The following is a description of a gene set: Hepatocellular carcinoma (HCC) is a highly heterogeneous disease, and prior attempts to develop genomic-based classification for HCC have yielded highly divergent results, indicating difficulty in identifying unified molecular anatomy. We performed a meta-analysis of gene expression profiles in data sets from eight independent patient cohorts across the world. In addition, aiming to establish the real world applicability of a classification system, we profiled 118 formalin-fixed, paraffin-embedded tissues from an additional patient cohort. A total of 603 patients were analyzed, representing the major etiologies of HCC (hepatitis B and C) collected from Western and Eastern countries. We observed three robust HCC subclasses (termed S1, S2, and S3), each correlated with clinical parameters such as tumor size, extent of cellular differentiation, and serum alpha-fetoprotein levels. An analysis of the components of the signatures indicated that S1 reflected aberrant activation of the WNT signaling pathway, S2 was characterized by proliferation as well as MYC and AKT activation, and S3 was associated with hepatocyte differentiation. Functional studies indicated that the WNT pathway activation signature characteristic of S1 tumors was not simply the result of beta-catenin mutation but rather was the result of transforming growth factor-beta activation, thus representing a new mechanism of WNT pathway activation in HCC. These experiments establish the first consensus classification framework for HCC based on gene expression profiles and highlight the power of integrating multiple data sets to define a robust molecular taxonomy of the disease.. from publication Hoshida Y, Nijman SM, Kobayashi M, Chan JA, Brunet JP, Chiang DY, Villanueva A, Newell P, Ikeda K, Hashimoto M, Watanabe G, Gabriel S, Friedman SL, Kumada H, Llovet JM, Golub TR (PMID 19723656) Genes from 'subtype S3' signature of hepatocellular carcinoma (HCC): hepatocyte differentiation. Human Gene Set: HOSHIDA_LIVER_CANCER_SUBCLASS_S3 species: Homo sapiens, and this is the list of marker genes: CGREF1, IMPA1, C8B, SLC7A2, ASGR2, SOD2, ALDH1B1, RBP5, MTHFS, ICAM3, RGN, F11, CA2, CYP21A2, AGL (amylo-alpha-1, 6-glucosidase, 4-alpha-glucanotransferase), FGG, ABCC6, COL18A1, SERPING1, KCNJ8, F2, SPAM1, GSTA2, APCS, DRG2, IQGAP2 (IQ motif containing GTPase activating protein 2), COX5B, SMARCA2, FMO4, CNGA1, TDO2, TOB1, CRABP1, PGRMC1, ATOX1, LONP1, PAH, CP, F5, TINAGL1, ARSA, KLKB1, ARG1, NDUFV2, IDH3A, SELENBP1, MYO1E, ACO1, NRG1, HSD17B10, IL6R, ALPL, GPX2, APOC2, CAT, ALDH7A1, TGFBR3, ASCL1, CD81, CYFIP2, ACOX1, BDH1, ECI1, SLC6A1, ADA2, FANCA, ADH4, PAPSS2 (NCBI Gene Id 9060), DNASE1L3, SHMT1, FXR2, APOC4, SERPINA3, DCAF8, MMUT, FH, ACADS, HADH, ETS2, MYLK (myosin light chain kinase), TMOD1, PGM1, EGFR, GSTO1, SLPI, GCHFR, NNMT, ATP5F1D, TMBIM6, HSD17B4, PTS, APOH, PCK2, FGB, ITIH3, NFIC, ACAA2, ACY1, ISG15, AQP7, PROS1, UQCRB, IDH2, HGD, NFIB, SOAT1, NHERF2, IGF1, IFIT1, SDC1, ARHGEF12, MTHFD1, LCAT, TCEA2, C1S (NCBI Gene Id 716), CBR1, ACADM, CRYAA, ASS1, GPX3, ACADVL, PON3, INSR, AKR1C1, ASL, GLYAT, ITPR2, ACOX2, RHOB, SDS, ATP5PF, CPA3, SORL1, CPS1, SPARCL1, AOC1 (NCBI Gene Id 26), ALDH1A1 (NCBI Gene Id 96075), AMFR, C1R, CRYM (NCBI Gene Id 1428), ECHS1, PNPLA4, PPP2R1B, LPIN1, ALDH4A1, EHHADH, CFH, IL32, SOD1, HMOX2, CD14, PLCG2, HPD, MT2A, SBDS, AZGP1, AMT, ABCB4, CYP2C9, C4BPA, PLA2G2A, EDNRB, HAAO, FKBP2, ALDH6A1, MAOB, ACADSB, VSIG2, DAO, MME, SRD5A1, ABHD2, ACSL1, SDHB, PIK3R1, CES1, MSMO1, RIDA, CFB, POLD4, BHMT, SLC35D1, QDPR, SHB, TST, PTGR1, SERPINC1, CPB2, LPIN2, ITIH4, ITIH1, C4A, SREBF1, SLC16A2, CYP3A7, IVD, ALDH3A2, IL13RA1 (interleukin 13 receptor subunit alpha 1), BLOC1S1, PLGLB2, GSTZ1, RNASE4, PCCB, EPHX1, CTSO, SLC10A1, ALDH2, BPHL, BTD, MAOA, BLVRB, RARRES2, ALAS1 (NCBI Gene Id 211), ALDOB, CXCL2, CPA4, HMGCS2 (NCBI Gene Id 3158), SULT2A1, DPAGT1, SLC2A2, GJB1, CYB5A, ZNF160, GCKR, GHR, PLG, FAH, HRG, GOT2, MGST2, ANXA6, ASGR1, SLC6A12, EMP2, KMO, CYP2J2, KNG1, CYP27A1, PCCA, SERPINA6, AGXT, CSTB, PCK1, SLCO2A1, GGH, CTH, ADH6 (NCBI Gene Id 130), EPAS1, DECR1, GCH1, NFKBIA, TJP2, APOA1, TPMT, SLC23A1, CD302, GPT, BAAT, FLT4, MAPRE3 (NCBI Gene Id 22924), PKLR, FOXO1, PDK4, SLC23A2, ADK, SELENOP